Given this list of marker genes CLSTN1, EEIG2, GLG1 (golgi glycoprotein 1), ID2, MAP3K1, KIF14, TIAM2, HTR7, FHIP2A, DNAJC3, GRPEL1, F13A1, MITF, MTOR, ZNF831 (zinc finger protein 831), UBE2D3, ICA1L, PWWP2A, ZNF780B, TMED1, NR2C1, IL6, ZC3H12A, PEX7, IGF1R, C9orf43, CREBRF, NFATC2, MTF1, ZNF385B, WNK3, HDDC3, SUSD4, ABCC1, SYCP2L, CSTF2, GREB1, SGMS2, GNAI3, NEK6, KLF3, DAZL, TMEM263, CMPK1, ALK, WDR47, JKAMP, ARMC8, FAM117B, MCM9, STX16, CREB5, CHL1, PID1, C2orf49, PLGLB2, PIM2, SORT1, FGD6, KCNS1, ITGA10, SNX4, EMCN, IRAK3, MDN1, HNF1B, MCAM, NUDT4, YIPF4, ZFHX4, USP14, FAM110C, EPB41L5, MTFR1, DENND11, CEP126, here is a description of the gene set: Human Gene Set: MIR4256 Genes predicted to be targets of miRBase v22 microRNA hsa-miR-4256 in miRDB v6.0 with MirTarget v4 prediction scores > 80 (high confidence targets). studied in species Homo sapiens from publication Chen Y, Wang X (PMID 31504780)